The following is a description of a gene set: species: Homo sapiens Any process that results in a change in state or activity of a cell or an organism (in terms of movement, secretion, enzyme production, gene expression, etc.) as a result of a myofibril being extended beyond its slack length. Human Gene Set: GOBP_RESPONSE_TO_MUSCLE_STRETCH, and this is the list of marker genes: NPPA, TCAP, PTK2, SLC8A1, DDR2, DMD, CAV3, TTN, EDN1, SLC9A1, RELA, RAF1, NFKBIA, ANKRD23 (NCBI Gene Id 200539), MAPK14, NFKB1, GPI, CSRP3, JUN, FOS, RYR2, CDH2, GSN (gelsolin), ANKRD1, CTNNB1, PIK3CA